The following is a description of a gene set: species: Homo sapiens Human Gene Set: GENTILE_UV_HIGH_DOSE_UP DNA damage caused by UV radiation initiates cellular recovery mechanisms, which involve activation of DNA damage response pathways, cell cycle arrest and apoptosis. To assess cellular transcriptional responses to UVC-induced DNA damage we compared time course responses of human skin fibroblasts to low and high doses of UVC radiation known to induce a transient cellular replicative arrest or apoptosis, respectively. UVC radiation elicited >3-fold changes in 460 out of 12,000 transcripts and 89% of these represented downregulated transcripts. Only 5% of the regulated genes were common to both low and high doses of radiation. Cells inflicted with a low dose of UVC exhibited transcription profiles demonstrating transient regulation followed by recovery, whereas the responses were persistent after the high dose. A detailed clustering analysis and functional classification of the targets implied regulation of biologically divergent responses and suggested involvement of transcriptional and translational machinery, inflammatory, anti-proliferative and anti-angiogenic responses. The data support the notion that UVC radiation induces prominent, dose-dependent downregulation of transcription. However, the data strongly suggest that transcriptional repression is also target gene selective. Furthermore, the results demonstrate that dose-dependent induction of cell cycle arrest and apoptosis by UVC radiation are transcriptionally highly distinct responses. from publication Gentile M, Latonen L, Laiho M (PMID 12907719) Selected genes up-regulated in WS1 (fibroblast) in response to irradiation with high dose UV-C., and this is the list of marker genes: LRBA, HBEGF, SFI1, ATF3, H2BC10, MMP3, RRAD, H2BC6, PLA2G6, PRSS3, COL13A1 (NCBI Gene Id 96775), IL11, NUPR1, TSC22D3, H2AC18, PMAIP1, HTR6, GADD45A, COX6A1, ISG15, FSTL3 (follistatin like 3), ELOB, SAT1